The following is a description of a gene set: species: Homo sapiens Any process that modulates the frequency, rate, or extent of antigen processing and presentation of antigen (peptide or polysaccharide) via MHC class II. Human Gene Set: GOBP_REGULATION_OF_ANTIGEN_PROCESSING_AND_PRESENTATION_OF_PEPTIDE_OR_POLYSACCHARIDE_ANTIGEN_VIA_MHC_CLASS_II, and this is the list of marker genes: TREM2, PYCARD, HLA-DOB, THBS1, HLA-DOA